The following is a description of a gene set: studied in species Mus musculus Mouse Gene Set: GOBP_T_CELL_CYTOKINE_PRODUCTION Any process that contributes to cytokine production by a T cell., and this is the list of marker genes: Lilrb4a, Il6, Il1r1, Slc11a1, Arid5a, Malt1, Il1b (NCBI Gene Id 16176), Tbx21, Map3k7, Smad7, Il18rap, Dennd1b, Vsir, B2m, Prkcz, Traf6, Sash3, Hfe, Il12a, Il12b, Ccl20, Slamf1, Foxp3, Fosl2, Nlrp3, Cd55b, Fzd5, Trpm4, Ccr2, Il4, Traf2, Ifnb1, Stard7, Lilrb4b, Il18r1, Xcl1, Arg1, Dlg1, Il18, Il31ra, Tnfsf4, Tnfrsf1b, Cd81, Gata3, Rsad2, Crlf2, Gba1, Kdelr1, Il25, Cd55